The following is a description of a gene set: RAB GEFs exchange GTP for GDP on RABs Mouse Gene Set: REACTOME_RAB_GEFS_EXCHANGE_GTP_FOR_GDP_ON_RABS studied in species Mus musculus, and this is the list of marker genes: Chm, Rab8a, Sbf2, Dennd6a, Ccz1, Rab27b, Ywhae, Rab3gap1, Rab10, Trappc10, Mon1b, Rab8b, Akt2, Gdi1, Dennd3, Rab3gap2 (NCBI Gene Id 98732), Trappc3, Dennd1c, Hps1, Trappc8, Rabgef1, Dennd2d, Sbf1, Rab3a, Rab18, Rab6a, Rab39, Rab5b, Madd, Trappc2l, Ric1, Trappc12, Rab31, Rab32, Dennd4c, Trappc1, Trappc13, Rin2, Ulk1, Rab3ip, Als2cl, Trappc6a, Trappc9, Als2, Dennd2b, Rin3, Trappc4, Rab7b, Rab39b, Gdi2, Rab6b, Rab1b, Trappc11, Rab14, Mon1a (NCBI Gene Id 72825), Dennd5a (DENN domain containing 5A), Rab35, Rab38, Rab9, Rinl, Ankrd27, Rab27a, Trappc2, Akt1, Dennd1b, Hps4, Rab7 (RAB7, member RAS oncogene family), Rab21, Dennd4a, Gapvd1, Trappc5, Dennd6b, Dennd5b, Rab12, Rgp1, Dennd2a, Rab5a, Rab3il1, Rab13, Dennd2c, Trappc6b, Rab1a, Rab9b, Dennd4b, Rab5c, Rin1, Dennd1a, Akt3, Chml